Given this list of marker genes MKKS, NPFF, PPARA, FBN1 (fibrillin 1), PRKCG, CARTPT, NPY, GHRL, NENF, GFRAL, BBS2, GDF15, BBS4, LEP (NCBI Gene Id 3952), SPX, MT3, UCN, GHSR, here is a description of the gene set: Human Gene Set: GOBP_REGULATION_OF_RESPONSE_TO_FOOD Any process that modulates the frequency, rate or extent of a response to a food stimulus. species: Homo sapiens